The following is a description of a gene set: This event has been computationally inferred from an event that has been demonstrated in another species.<p>The inference is based on the homology mapping from PANTHER. Briefly, reactions for which all involved PhysicalEntities (in input, output and catalyst) have a mapped orthologue/paralogue (for complexes at least 75% of components must have a mapping) are inferred to the other species. electronically inferred by orthology from the curated human pathway Reactome Pathway: B-WICH complex positively regulates rRNA expression part of: Positive epigenetic regulation of rRNA expression species: Mus musculus, and this is the list of marker genes: Ercc6, Mybbp1a, Polr1c, Tbp, Smarca5, Polr2f (NCBI Gene Id 69833), Polr2k, Polr2e (polymerase (RNA) II (DNA directed) polypeptide E), Ddx21, Polr2l, Ep300, Taf1d, Polr1g, Polr1e, Polr1h